Given this list of marker genes ATR, AGPAT2, TALDO1, VAMP7, NDUFB11, HSD3B2, FGFR2, PPARG, PEX5, GATA4, SOX9, AR, SRY (sex determining region Y), KAT6B, ORC1, WWOX, PEX12, UBE3B (ubiquitin protein ligase E3B), ORC6, PEX10, CD96, CDT1, DHX37, PEX26, FRAS1, CYP11A1, PEX1, ZFPM2, PEX16, PEX13, ESCO2, INSR, PPP1R12A, MINPP1, NR5A1, UBR1, CEP152, PEX3, CYP11B1, COX7B, CAVIN1, CDC6, CCNQ, FOS, MAP3K1 (mitogen-activated protein kinase kinase kinase 1), PEX19, ARID1B, PEX2, MED25, WT1, ORC4, GAD1, PEX6, BSCL2, CDC45, PEX11B, ATIC, CAV1, FDXR, PEX14, VAC14, NR0B1, HCCS, FIG4, TOE1, GMNN, POR, TRAIP, RSPO1 (NCBI Gene Id 284654), DHCR7, here is a description of the gene set: Human Gene Set: HP_CLITORAL_HYPERTROPHY species: Homo sapiens Clitoral hypertrophy Hypertrophy of the clitoris.